Given this list of marker genes KCNJ11, MYBPC3, MYH3, NPR2, TPM2, TCAP, ACTG2, WWTR1, FXYD2, CACNG7, MYL6B, ITGB5, KCNE3, TMOD2, SCN4A, KCNE5, SLC8A3, ATP1A3, SCN5A, ACTA1, CORIN, ACTN3, KCNJ14, ITGA1, KCNK6, CALM1, TNNC1, FGF14, ITPR1, CACNG8, ANXA6, KCNK5, VCL, SRI, MYL4, ATP2B4, ATP1A2, ITPR3, TMOD3, KCNK16, TMOD4, MYL3, DYSF, TPM1, MYH11, MME, FXYD6, PXN, GUCY1A2 (NCBI Gene Id 2977), MYL9, KCNK7, SLN, KCNK4 (potassium two pore domain channel subfamily K member 4), GUCY1A1, TLN1, ATP2B1, KCNJ2, SCN2B, NPR1, DMD, SCN2A, KCNK1, FGF13, FGF11, FXYD7, KCNJ4, PDE5A (NCBI Gene Id 8654), CAMK2G, KCNA5, TMOD1, KCNK2, KCNIP4, ATP1A1, CALD1, KCNJ12, CASQ2, ATP2A2, CACNB1, MYH8, TNNC2, FXYD3, SLC8A2, HIPK2, FGF12, MYL7, CES1, ACTC1, TRPC1, KCNK17, CAMK2A (calcium/calmodulin dependent protein kinase II alpha), ACTN2, ATP1B2, KCNK3, NKX2-5, SCN1A, RYR3, CLIC2, MYL6, MYL12A, CACNA1H, CAV3, ACTA2, CAMK2B, KCNIP2, STIM1, TTN, CACNA1I, KCNIP1, LMOD1, RYR2, KCNK12, KCNK15, KCNE1, KCNQ1, MYH6 (myosin heavy chain 6), TRIM72, ATP2B2, KCNIP3, TNNT2, SCN4B, FXYD1, KCNK9, NPPC, MYLK, CACNA1C, KCND3 (potassium voltage-gated channel subfamily D member 3), PLN, MYBPC1, SCN8A, PRKACA, GUCY1B1, KCNK13, SCN3A, MYL12B, ATP1B3, TNNI2, MYL1, PAK2, SCN9A, RYR1, CAMK2D, TNNT1, TNNT3, ATP1B1, KCNE2, ORAI1 (NCBI Gene Id 84876), KCNK18, DES, SORBS3, ANXA2, HIPK1, KCNH2, AKAP9, CACNA1G, FXYD4, ASPH, SCN10A, SLC8A1, TBX5 (T-box transcription factor 5), NOS1, ATP2A1, PAK1, MYL2, GATA4, TNNI1, FKBP1B, ORAI2, CACNG4, KCND2, MYL5, MYL10, VIM, ITPR2, SCN7A, MYBPC2, TPM4, MYL11, TPM3, DMPK, KCNE4, ATP2A3, ANXA1, CACNG6, CACNB2, SCN11A, AHCYL1, NEB, ATP2B3 (NCBI Gene Id 492), TRDN, ALDH2, GUCY1B2, TNNI3, CACNA2D2, ATP1A4, KCNK10, SCN1B (sodium voltage-gated channel beta subunit 1), KCND1, RANGRF, CASQ1, ABCC9, KAT2B, NPPA, SORBS1, SCN3B, here is a description of the gene set: studied in species Homo sapiens In this module, the processes by which calcium binding triggers actin - myosin interactions and force generation in smooth and striated muscle tissues are annotated. Cardiac conduction, also covered here, depends on coordinated action potentials that spread through tightly coupled cardiac cells to ensure the normal sequence of atrial and ventricular contraction and to allow rapid responses to changes in autonomic tone. The ventricular myocyte action potential consists of five phases: a K⁺-determined resting membrane potential (phase 4), rapid Na⁺-dependent depolarization (phase 0), brief initial repolarization due to outward ion currents (phase 1), a plateau sustained by balanced Ca²⁺ influx and K⁺ efflux that supports contraction (phase 2), and K⁺-mediated repolarization back to the resting potential (phase 3). Reactome Pathway: Muscle contraction